Given this list of marker genes ZNF22, SEMA4F, DDIT4, RGS14, ITGB7, NDRG2, FXYD5, GRAP2, RGS7, KLF13, ACVRL1, TGIF1, SLC25A4, TMEM131, PBX2, CRK, RPL22, CD9, RCAN3, KIF23, ZFP36, CYB5A, POLG, TBXA2R, RASA3, ICAM2 (intercellular adhesion molecule 2), GGT5, CD99L2, POLE2, ANGPTL2, ALYREF, BTF3L4, F2RL1, ANP32A, LRRC8A, ABCG2, SHE, LPP, VSNL1, COX8A, TNFAIP8L1, MAP4K4, HSDL2, RBM38, ADRB2, TDRP, ITGA6, MFHAS1, HMGN5, MYB, CINP, BANP, ADK, DAG1, NDRG1, CYTIP, KLF2, TLE1, PAFAH2, RPS26, CD247, FAS, GPR83, RPL30, PDLIM4, MYC, ARHGAP21, RPS16, NDRG3, TMC6, TUBB6, HOXD1, CPSF2 (cleavage and polyadenylation specific factor 2), TUBA1A, GLO1, RPS3A, PPIC, FBXO21, SCAF8, METTL8, NSDHL, RFLNB, UTP18, CDK16, WDR75, DHCR24, CNN3, DNAH8, SHOC2, NPC2, ITM2A, MYH9, PATJ, ACTN1, SPSB1, TAF1C, APEX1, SLC9B2, G0S2, IL6R, KLF7, FOS, TSPAN32, GADD45A, SGK1, IGF1R, TTC39B, KCNAB2, UTP20, MAP7, RAB3IP, SERPINI1, GCOM1, SRPK1, NACC2 (NCBI Gene Id 138151), ALAS2, RGS16, NAV2, TSPAN6, IL6ST, SETD4, TULP3, GART (phosphoribosylglycinamide formyltransferase, phosphoribosylglycinamide synthetase, phosphoribosylaminoimidazole synthetase), HOXA5, SPICE1, SSBP2, KRT25, SCG5, EMP3, SMAD4, IFT25, UHRF1, ABHD14A, SERAC1, GCLM, CYP2S1, SQLE, WASHC3, SELL, F2RL3, S1PR1, ADCY6, SOCS3, NOLC1, CRIP1, CRTAM, RASGRP2, SKP1, HNRNPA1, ST8SIA1, GRK6, PDLIM1, WEE1, PLEC, RPL28, TRAF5, CCR7, SPTAN1, ENTPD6, DGKA, DNTT, CASK, KCNN4, NSG2, STRN4, SLC7A5, NR4A1, CD5, GCSH, S1PR4, RBM25, ARL4C, PRKD2, PTPRA, SLC30A4, PDGFRB, GNB4, FOXP1, TPR, NEDD4L, GABRR2, PDE4B, ST3GAL1, SFMBT2, TMEM71, SIGMAR1, NTMT1, IPO4 (importin 4), KPNA4, MBTD1, SMC4, PLP2, RGS10, LGALS4, RGCC, IRF6, ID3, ABCC5, TUBB2A, EIF4ENIF1, here is a description of the gene set: Myeloid-derived cells comprising the tumor stroma represent a heterogeneous population of cells critical to the structure, function and growth of established cancers. We have recently found that engineering tumor-specific CD8+ T cells to secrete IL-12 (IL-12TD) can lead to striking improvements in T-cell activity against established melanomas in murine models. Surprisingly, IL-12-dependent enhancement of CD8+ T-cell anti-tumor function did not occur through direct ligation of receptors on lymphocytes or NK cells. Instead, IL-12 sensitized host bone marrow-derived tumor-stromal cells, partly through interferon-gamma, to indirectly enhance the effects of adoptively-transferred T cells. Direct presentation of antigen by tumor was not necessary, but MHC class I expression on endogenous cells was essential for IL-12 mediated anti-tumor enhancements. Upon successful treatment with IL-12TD cells, we observed the selective elimination of tumor-infiltrating CD11b+ F4/80+ macrophages, CD11b+/ClassII+/CD11c+ dendritic cells and CD11b+/Ly6C+/Ly6G- but not CD11b+/Ly6C+/Ly6G+ myeloid-derived suppressor cells within regressing lesions. These results are consistent with a model whereby IL-12 triggers the maturation of myeloid-derived cells into competent antigen cross-presenting cells. Licensed recognition of these antigens by effector T cells may in turn trigger the collapse of the tumor stroma and aid in the regression of large vascularized lesions. Human Gene Set: GSE29164_CD8_TCELL_VS_CD8_TCELL_AND_IL12_TREATED_MELANOMA_DAY3_DN Genes down-regulated in B16 melanoma at day 3 of adoptive transfer treatment: mock versus therapy. species: Homo sapiens from publication Kerkar SP, Goldszmid RS, Muranski P, Chinnasamy D, Yu Z, Reger RN, Leonardi AJ, Morgan RA, Wang E, Marincola FM, Trinchieri G, Rosenberg SA, Restifo NP (PMID 22056381)